Given this list of marker genes CCT2, ISY1-RAB43, PMS1, TIMM10B, SFSWAP, MST1P2, TXN2, RPUSD4, MMAB, MYLK-AS1, ALDH1A2, TSN, PIGO-AS1, ARFIP2, SLC35B1, RPL7L1, EDC3, KCTD21, LINC01635, SLC12A9, HOXA9, PARP16, CROCCP2 (NCBI Gene Id 84809), ORMDL1, SUPT7L, LINC02889, SMU1, SLC4A1AP, FAM118B, HOXB8, RNU6-952P, HACD2, RPL7P30, HOXA-AS3, RPL6, VPS37A, USP35, MIR3913-1, HOXA11-AS, LINC00881, POC5, RCCD1, NAPA, DYNC2I2, TRMO (NCBI Gene Id 51531), PLSCR4, MVK, MAGOHB, MGC32805, CDK7, PIGO, SNORA24B, CNOT7, ISY1, KHDC4, PTPN11, here is a description of the gene set: Human Gene Set: HOXA13_TARGET_GENES from publication Yevshin I, Sharipov R, Kolmykov S, Kondrakhin Y, Kolpakov F (PMID 30445619) Genes containing one or more binding sites for (HOXA13) in their promoter regions (TSS -1000,+100 bp) as identified by GTRD version 20.06 ChIP-seq harmonization. studied in species Homo sapiens